The following is a description of a gene set: species: Mus musculus Mouse Gene Set: GOBP_POSITIVE_REGULATION_OF_RESPONSE_TO_EXTERNAL_STIMULUS Any process that activates, maintains or increases the rate of a response to an external stimulus., and this is the list of marker genes: Ifih1, Bcl10, Htr2a, Ager, Klrk1, Rnf125, Zdhhc3, Naglu, Pum2, Mif, Gfi1, Fgf10, Fpr-rs3, Ffar3, Xcl1, Artn, Casr, Optn, Gdi1, Tlr3, Peli3, Braf, Fcnb, Card9, Gbp2, Ptpn11, Phb1, Ccl19-ps4, Traf3 (NCBI Gene Id 22031), Aars2 (alanyl-tRNA synthetase 2, mitochondrial), Alox5ap, Dpp4, P2ry12, Vamp8 (NCBI Gene Id 22320), H2-M3, Polr3g, Tnfsf14, Trim30b, Pgf, Trim32, Ifi204, Dscam, Cxcr2, Lgmn, Nfkbia, Aif1, Rnf31, Shh, C3, D1Pas1, Ptger3, Gbp5, Mmp12 (NCBI Gene Id 17381), Fn1, Itga2, Trem3, Il21, Tifab, Nupr1 (nuclear protein transcription regulator 1), Znfx1, Ldlr, Il6, Ccl19-ps1, Lta, Sarm1, Ccl2, Tmem102, Mstn, Rps6ka3, Klre1, Cmklr1, Cpt1a, C5ar1, Tmsb4x, Ripor2, Fpr-rs4, Cgas, S1pr1, Lgals2 (NCBI Gene Id 66535), Matr3 (matrin 3), Cdh13, Klrd1, Nagk, Ighg2b, Gimap3, Pde5a, Plscr1, Hpx, Banf1, Ifi214, Ppp2ca, Znrf1, Trim62, Vav1, Tnfsf18, Ap1g1, Hcfc2, Xrcc6, Gm12250, Rnf135, Pomc, Nop53, Ptk2, Polr3b, Vegfa, Tnfaip3, Irak1, Park7, Lrrk2, Casp12, Ptprj, Dhx58, Sh2d1b1, Nr1h3, Klri2, Tax1bp1, Pdgfb, Nectin2, Ttbk1, Pja2, Lrp1, Stx4a, Rbm47 (RNA binding motif protein 47), Ccl5, Raet1e, Zdhhc18, Xrcc5, Smad3, Serpine1, Tafa3, Unc93b1, C2cd4a, Ogt, Arrb2, Sin3a, Klrc2, Klk7, Med1, Pdgfd, Trim3, Irgm2, Clec4e, Cxcl14, Cxcl1, Dhx9, Oas1f, Rasgrp1, Stk24, Tnip1, Tomm70a, S100a14, Aim2 (NCBI Gene Id 383619), Eif2ak2, Vegfd, Pcbp2, Nlrc3, Ccr4, Trim25, Rnf115, Gbp7, Ecsit, Lyplal1, Klk5, Fgf18, Cd300ld3, Prkdc, Pdcd4, Trim30a, Ifi211, Lrrfip2, App, Nlrp1b, Hexim1, Arg1, Scg2, Usp50, Nr1h4, Met, Lrsam1, Akt2, Srebf1, Nmi, Fpr-rs7, Ctsc, Tkfc, Cadm1, Adam8, Ddx60, Spsb3, Rarres2, Scarf1, Pik3r1, Riok3, Clock, Tnfrsf11a, Mmrn2, Casp1, Zdhhc5 (NCBI Gene Id 98978), Nlrc4, Thbs4, Nlrp10 (NLR family, pyrin domain containing 10), Akt1, Zbp1, Fcgr1, Tifa, Ctss, Tnf, Gprc5b, Ifi206, Polr3f (NCBI Gene Id 76836), Rsad2, Tspan6, Cav1, Gpatch3, Lats1, Csnk1a1, Lag3, Lamp1, Lacc1, Wnk1, Pdgfra, Cactin, Klrb1c, Gbp2b, Oas1a, Pgc, Oas1g, Ly86, Zdhhc12, Rela, Pdpk1, Gbp3, Rnf144a, Cd28, Ptgs2, Lgals1, Ufd1, Washc4, Plat, Ccr7, Sqstm1, Fkbp1b, Snca, Ifi209, Tlr11, Ptpn22, Vegfb, Trim12a, Ifi205, Adora3, Tmem126a, Nono, Oas1e, Ntrk3, Il18rap, Slamf1, Elp6, Ccl19-ps6, Usp27x, Ifi203-ps, Rbm14, Hyal2, Nrp1, Defb25, Vegfc, Pde2a, Il17ra, Lamp2, Plau (plasminogen activator, urokinase), Il16, C3ar1, Ppbp, Ikbke (NCBI Gene Id 98726), Fadd, Ets1, Gpr4, Sirt2, Rtn4, Smpdl3a, Ccl24, Pla2g7, Tpbg, Edn1, Lpar1, Tlr2, Tarbp2, Flna, Oas3, Lbp (NCBI Gene Id 16803), Ywhae, Pla2g5, Nppa, Slc15a2, Pik3cg, Cd24a, Cd74, Prkca, Irf4, Parp1, Oxsr1, Il12a, Src, Scimp, Oas1h, Irf1, Serpinf2, Cptp, Emilin2, Cd226, Cxcr3, Traf6, Rigi, Trim30d, Kars1, Prkce, Hspa8, Cd86, Csf1r, Il18, Mapk1, Usp15, Nek7, Brcc3, Hsp90aa1, Hmgb2, Mospd2, Cx3cl1, Grn, Mavs, Irf2, Ano6, Cd14, Pik3ap1, Lrrc14, C1qbp, Ccr1l1 (NCBI Gene Id 12770), Tnfsf11, Gpsm3, Fgfr1, Tasl, Klrc3 (NCBI Gene Id 58179), Csf1, Dysf, Sash1, Pdgfrb, Rac2, Rnf170, Ticam1, Cd300a, Slamf6, Erbin, Tlr12, Ccl21a, Ptk2b, Nod1, Rab11fip2, Rps19, Ccr1, Colec12, Sting1, Pvr, Cxcl10, Abhd17a, Ccl21f, Cd47, Fem1a, Casp6, Ndel1, Lsm14a, Mmp8, Adam10, Tlr9, Txk, Usp29, Slc15a3, Il17a, Trim12c, Mbl2, Otulin, Fabp4, Lrrc19, Slc15a4, Ninj1, Il17f, Ddx3x, Sucnr1 (NCBI Gene Id 84112), Dapk2, Sfpq, Ticam2, Ccl26, Nrg1, Stk39, Ube2k, Trim11, Trim56, Hmgb1, Npy5r, Nckap1l, Atat1, Mcu, Tril, Irak3, Oas1b, Reg3g, Aoc3, Cd160, Plg, Thbs1, Wnt5a, H2-T23, Phb2, Ap3b1, Nkg7, Abcc1, Crtam, Fcer1a, Plcg2, Perp, Trem2, Ccl19-ps3, Ptprs, Hspd1, Tab1, Trem1, S100a8, Btk, Tlr6, Ccl21b, Fcer1g, Mapkapk3, Trex1, C2cd4b, Pqbp1, Chuk, Zdhhc9, Tac1, P2rx7, Cttn, Letmd1, Ripk1, Ccr5, Trim31, Nedd9, Pla2g3, Tyrobp, Ifi213, Ccl7, F7, Appl2, Unc13b, Mdk, Ppp6c, Esr1, Map3k7, Oas1d, Ido1, Zdhhc1, Lyn, Nfkbil1 (NCBI Gene Id 18038), Tlr13, Cxcl12, Tradd (TNFRSF1A-associated via death domain), Trpv4, Bpifb1, Ccdc134, Nlrp6, Trim5, Tyro3, Apoh, Smpdl3b, Nlrc5, Cd300lf, Stmp1, Cxcl17, Ipo5, Rab7b, Slc19a1, Cpb2 (NCBI Gene Id 93820), Cd36, Tnip2, Mfhas1, Stx3, Ncr3-ps, Cxcl13, P2rx4, Oasl1, Brcc3dc, Xiap, Raet1d, Zcchc3, Fbxl2, Clec7a, Cxcr4, Zp3, Ccl19, Ddt, Ccl3, Lilra5, Inava, Fcna, Clpb, Zfp580 (zinc finger protein 580), Ccr2, Calr, Trim15, Ptn, Gkn2, Dnm1l, Trim6, Il17rb, Myd88, Ifi207, Lgals9, Ednra, Nr1d1, Lrch4, Prkd1 (NCBI Gene Id 18760), Slit2, Cd274, Tnip3, Ripk2, Lgr4, Mefv, Trim41, Gimap5, Fpr2, Klrc1, Aurkb, Rab34, Pycard, Fcgr3, Megf8, Slc46a2, Ccr6, Alpk1, Edn3, Ptger4, Irak2, Ccl21e, Snx4, Stat5b, Ffar2, Edn2, Casp4, Emilin1 (NCBI Gene Id 78939), Tslp, Lats2, S100a9, Sh2d1a, Zc3hav1, Tgfb1, Bmpr2, Irgm1, Epg5, Gpr108, Ltf, Ighg1 (NCBI Gene Id 16017), Adora2b, Ereg, Adam17, Pspc1, Ifng, Igf1r, Cd180, Tlr8, Stat5a, Arf6, Smoc2, Kat5, Mapk8 (NCBI Gene Id 26419), Ulbp1, Hspb1, Clec4n, Swap70, Irf7, Lpl, Acod1, Rnf34, Gps2, Mapk3, Ifi208 (NCBI Gene Id 100033459), Clnk, Akirin2, Gsdmd, Ppt1, Bmp6, Sec14l1, Stap1, Oas1c, Otud4, Mndal, Map3k8, Fgf16, Traf3ip3, Nlrx1, Ccn4, Tnfsf4, Mark4, Trim30c, Vtn, Snai2, Akirin1, Syk, Wasl, Ankrd17, Nploc4, Cntf, Osm, Wdfy1, Znrf4, Kcnn4, Rac1, Sema5a, Mapkapk2, Tlr1, Prkd2, Rftn1, F2rl1, Igtp, Ccl1, Sh2d1b2 (SH2 domain containing 1B2), Nfkbiz, Gramd4, Camk1d, Itch, Nlrp3, Dhx33, Hspa1b, Cyba, Nlrp1a, Tlr5, Creb3, Peli1, Pum1, Casp3, Tnfrsf1a, Fpr-rs6, Tlr4, Il4, Spi1, BC037156, Il23a, Rnf185, Cd81, Cnr1, Ifi35, Cebpa, Il34, Ly96, Dab2ip, Fgf2, Polr3d, Becn1, Ifi203, Cebpb, Cx3cr1, Polr3c, Rasgrp4, Treml4, Il1b, Tlr7, Klri1, Il33, Napepld, Gm15441, Ppm1f, Kcnk13, Tbk1, Il1rl1, Sell, Ptgs2os, Parp9, Gas6, Tiam1, Nod2, Fosl1, Ccl19-ps5, Kdr, Appl1, Usp17le, Tirap, Irf3, Setd4 (SET domain containing 4), Zdhhc4, Ccl21d, Hrg, Ubqln1, Camk2n1, Havcr2, Ntf3, Kcnj8, Il12b, Flot1